Given this list of marker genes SOX15, CKS1B, CNTN4, ITGA2, GDPD2, ALDH7A1, MOB1A, DMRTA2, TPD52L1, SDC4, NBEA, CPAMD8, THBS1, CAPS, IMPA2, RAET1G, HERPUD1, ATP5PF, GPM6A, C12orf75, OCIAD2, ADH7, CRIM1, DDIT3, MRPS6, DYNLRB1, ELOB, RFK, ATP6V1E1, UBE2C, SCP2, PIM1 (Pim-1 proto-oncogene, serine/threonine kinase), ZFP36, ACYP1, ELF3 (E74 like ETS transcription factor 3), LSM3, EGOT, ARHGEF3, IFT25, EID3, ATP1B3, LRRC8D (leucine rich repeat containing 8 VRAC subunit D), BLCAP, RAPGEF3, HSP90AA1, C16orf74, FAM169A, CLEC7A (NCBI Gene Id 64581), ITGB4, ITGA3, PRDX5, ASCL2, FHOD3, ATP5MC3, PRDX1, CKAP4, NRG1, KIF21A, ADI1, ATP5MJ, CPXM2, CRLF1, UPK1B, NEDD9, RHOU, TUBB4B, HSPA2, GAS1, BCO2, ATP23, KLF10, PKM (pyruvate kinase M1/2), H2AZ1, PYCR2 (NCBI Gene Id 29920), GSTP1, ATF3, GADD45B, CAPG, COL7A1, MRPS10, ARPC2, EGR1, SMIM30, TMEM14A, MT1E, ARHGAP12, TP63, KRT3, LSM5, TFRC, CAV2, FOSB, ITGAV, ASS1, ATP5MF, PTGES, EXOSC7, PAX6, SYT8, MRPL33, NREP, TGM2, CRYBG1, TUBB, UACA, PRDX2, HRK, HCAR3, HSPH1, NAA38, DUSP23, UBE2Q2, IL20RB, TOP2A, GPRC5A, here is a description of the gene set: Human Gene Set: GAUTAM_EYE_CORNEA_TGFBI_HIGH_EPITHELIAL_CELLS Occular cell types curated from Gautam and Hamashima et al. Multi-species single-cell transcriptomic analysis of ocular compartment regulons studied in species Homo sapiens from publication Gautam P, Hamashima K, Chen Y, Zeng Y, Makovoz B, Parikh BH, Lee HY, Lau KA, Su X, Wong RCB, Chan WK, Li H, Blenkinsop TA, Loh YH (PMID 34584087)